Given this list of marker genes ABCA7, PSEN1, PSEN2, TREM2, APP, TOMM40, SORL1, here is a description of the gene set: Finger agnosia studied in species Homo sapiens The examiner identified the inability to name, move, or touch specific fingers. Human Gene Set: HP_FINGER_AGNOSIA